Given this list of marker genes CDS2, PGS1, PLD2, PLD4, PLD1, PTPMT1, PLD3 (phospholipase D family member 3), PLD6, here is a description of the gene set: Synthesis of PG Human Gene Set: REACTOME_SYNTHESIS_OF_PG studied in species Homo sapiens